The following is a description of a gene set: The series of molecular signals initiated by apolipoprotein A-I binding to its receptor on the surface of a target cell, and ending with the regulation of a downstream cellular process, e.g. transcription. species: Mus musculus Mouse Gene Set: GOBP_APOLIPOPROTEIN_A_I_MEDIATED_SIGNALING_PATHWAY, and this is the list of marker genes: Abca7, Itgav, Abca1, Itgb3, Rhoa